The following is a description of a gene set: Human Gene Set: MIR122_3P studied in species Homo sapiens from publication Chen Y, Wang X (PMID 31504780) Genes predicted to be targets of miRBase v22 microRNA hsa-miR-122-3p in miRDB v6.0 with MirTarget v4 prediction scores > 80 (high confidence targets)., and this is the list of marker genes: SMURF2, MEF2C (myocyte enhancer factor 2C), LRRC17, FBXO25, NUDT21, ZNF805, SRF, POC1B